The following is a description of a gene set: Human Gene Set: GSE43955_TGFB_IL6_VS_TGFB_IL6_IL23_TH17_ACT_CD4_TCELL_52H_DN Genes down-regulated in CD4 T helper cells Th17 (52h): TGFB1 and IL6 versus TGFB1, IL6 and IL-23. Despite their enormous importance, the molecular circuits that control the differentiation of Th17 cells remain largely unknown. Recent studies have reconstructed regulatory networks in mammalian cells, but have focused on short-term responses and relied on perturbation approaches that cannot be applied to primary T cells. Here, we develop a systematic strategy – combining transcriptional profiling at high temporal resolution, novel computational algorithms, and innovative nanowire-based tools for performing gene perturbations in primary T cells – to derive and experimentally validate a temporal model of the dynamic regulatory network that controls Th17 differentiation. The network is arranged into two self-reinforcing and mutually antagonistic modules that either suppress or promote Th17 differentiation. The two modules contain 12 novel regulators with no previous implication in Th17 differentiation, which may be essential to maintain the appropriate balance of Th17 and other CD4+ T cell subsets. Overall, our study identifies and validates 39 regulatory factors that are embedded within a comprehensive temporal network and identifies novel drug targets and organizational principles for the differentiation of Th17 cells. studied in species Homo sapiens from publication Yosef N, Shalek AK, Gaublomme JT, Jin H, Lee Y, Awasthi A, Wu C, Karwacz K, Xiao S, Jorgolli M, Gennert D, Satija R, Shakya A, Lu DY, Trombetta JJ, Pillai MR, Ratcliffe PJ, Coleman ML, Bix M, Tantin D, Park H, Kuchroo VK, Regev A (PMID 23467089), and this is the list of marker genes: PSMD12, PPIC, ST6GAL1, CPEB2, SKIL, GOLPH3, PRKAR1A, WSB1, FJX1, CD5L, IRF7, SOWAHC, MTPN, TMEM230, FOXH1, BIRC3, RHOQ, CLEC4E, LSM14A, CGGBP1, SMAD5, IRS2, HGF, NR2F1, PRDM1, PPIE, ZFR, EXOC4, POSTN, RCL1, LPL, PSMA3, PTER, RNF138, PLEC, TNKS2, ALDH9A1, NOP58, NAV2, KIF5B, ANXA5, POLE2, CLPP, TRPC6, DUSP1, HAX1, NOG, TNF, XPO1, PDK3, FGFR1, CDKN1C, BOLA2, JAK2, COL11A2, MARCKS, RGS2, DTD1, CYB5R4, PEX5, TENT5C, PHLDA1, IL10, LYST, NR1H3, IL7R (NCBI Gene Id 3575), NID2, RBBP4, MMP14, PLSCR1, ALDH1A1, ASF1B, GTF2A1, EHD1, ADAM8, ZFP36, TFDP1, ZMYND11, CAPZB, PIK3CD, PAM, TBL1XR1, RCN2, TNFRSF11A, CD300C (NCBI Gene Id 10871), CDC42EP4, RSPO2, TUG1, FOXK1, GNAS, FSTL1, CCN2, MEST, SYT7, PTK7, IFI27L2, MKI67, ACSL4, EIF1AX, DPP6 (NCBI Gene Id 653748), APBB2, ARHGEF28, DUSP16, CYFIP1, TAX1BP1, FLNB, ZFP62, ABCD3, APAF1, NRP1, TMEM147, SLC12A7, CUL3, CHUK, YBX1, LAT2, VAMP7, SOS2, BASP1, ZFAND5, LY86, CLEC3B, KCNA3, PSEN2, PKP2, CXCL9, MFSD14B, PRDX5, CD44, IL13RA1, ZNF282 (zinc finger protein 282), NSMF, GSPT1, AIFM1, PTGS2, RNF38, RCAN1, FOXJ1, ITGA5, SSB, CTSH, FXYD1, CD72, VBP1, CDK14, BST1, PELI1 (pellino E3 ubiquitin protein ligase 1), PRP4K, CST3, MAP2K3, AHR, NFIA, HCCS, ZRSR2, WRN, RTN4, GPR65, MDFIC (MyoD family inhibitor domain containing), LPCAT3, BMP2K, SPATA13, CDIPT, MSR1 (macrophage scavenger receptor 1), ATP7A, PTGER4, NXN, RNF19B, PPP1R2P1, POU3F1, ZBTB16, CLIC4, EFNB2, DNAAF10, GSTZ1, OLR1, ATP11A, MLLT3, AKR1B15, RCBTB1, PLS3 (plastin 3), EBNA1BP2, SLC27A1, SNAPC2, CTSE, KLHL7, ATXN10, UCHL5, SENP3, CASP4, REXO2, SF3B5, PPP1CB, NAMPT, WIPF1, GCH1, ECM1, TPD52, C1QB, TOR1AIP2, EGR1